The following is a description of a gene set: Abnormal transferrin isoform profile consistent with a type I congenital disorder of glycosylation. In the traditional nomenclature for congenital disorders of glycosylation, absence of entire glycans was designated type I, and loss of one or more monosaccharides as type II. Type I transferrin isoform profile studied in species Homo sapiens Human Gene Set: HP_TYPE_I_TRANSFERRIN_ISOFORM_PROFILE, and this is the list of marker genes: ALG13 (NCBI Gene Id 79868), SSR4, ALG1 (NCBI Gene Id 56052), DPM1 (dolichyl-phosphate mannosyltransferase subunit 1, catalytic), RFT1, DDOST, DPAGT1, MPI, ALG11, DPM2, ALG3, MAGT1, MPDU1, ALG8, SRD5A3, DOLK, PMM2, ALG12 (NCBI Gene Id 79087), ALG2, DPM3, ALG9, ALG6